Given this list of marker genes secE, sodC, MT2748, trx-2, ahpD, msrA, secY, Rv2895c, LTF, dlaT, irtB, trxB, secD, secF, adhE2, irtA, secA1, trxA, secA2, bfr, oppC, bfrB, glbN, oppD, lpdC, oppB, sodB, ggtA, tpx, secG, oppA, ahpC, ahpE, fgd1, katG, here is a description of the gene set: Reactome Pathway: Latent infection - Other responses of Mtb to phagocytosis part of: Infection with Mycobacterium tuberculosis <i>Mtb</i> encounters a vastly changed environment, soon after it gets internalized by macrophages. The compartment it resides in, the phagosome, is acidified and devoid of important metal ions. It is flooded with reactive oxygen and nitrogen species. And steps will be soon taken by the macrophage to "mature" the phagosome with all kinds of lysosomal digestive enzymes. However, unlike most other bacteria species <i>Mtb.</i> has evolved solutions to each of these threats and, after making sure these are installed, it soon will enter a dormant state (de Chastellier, 2009; Flannagan et al, 2009). A combination of the host defense and the response of the infecting bacillus (active and passive) ensure suppression of bacterial metabolic activity and replication, resulting in a non-replicating state. <br><br> studied in species Homo sapiens